The following is a description of a gene set: Genes down-regulated in CD8 T cells, acute infection with LCMV-Armstrong: effectors at day 6 versus memory at day 30. Human Gene Set: GSE41867_DAY6_EFFECTOR_VS_DAY30_MEMORY_CD8_TCELL_LCMV_ARMSTRONG_DN species: Homo sapiens from publication Doering TA, Crawford A, Angelosanto JM, Paley MA, Ziegler CG, Wherry EJ (PMID 23159438) During acute viral infections, naïve CD8+ T cells differentiate into effector CD8+ T cells and, after viral control, into memory CD8+ T cells. Memory CD8+ T cells are highly functional, proliferate rapidly upon reinfection and persist long-term without antigen. In contrast, during chronic infections, CD8+ T cells become “exhausted” and have poor effector function, express multiple inhibitory receptors, possess low proliferative capacity, and cannot persist without antigen. To compare the development of functional memory T cells with poorly functional exhausted T cells, we generated longitudinal transcriptional profiles for each., and this is the list of marker genes: LENG8, CPSF7, MCL1 (MCL1 apoptosis regulator, BCL2 family member), RPS27, KRTCAP3, TRAPPC8, HPCAL1, UCKL1, ITK, ATP2A3, UGCG, CHFR, SYF2, VAT1, NRM (NCBI Gene Id 11270), DDX6, CCR7, NUB1, ZFAND6, DUSP5, CLINT1 (NCBI Gene Id 9685), HDAC5, PHC2, INPP5F, WIPI2, PRKCZ, NFE2L2, INPP4A, EIF1, INPP5K, IRF8, BCL10, CD79A (NCBI Gene Id 973), PDE2A, TPK1, UBL3, SIDT2, PCNX3, PHF21A, SMC6, RASA3, TNRC6B, RELB, TAOK3, MAP4K3, RYBP, SPRY1, CD28, ANGPTL1, MYH9, NCOR1, PPP1R16B, APC, CCNI, TXNDC16, ABHD17B, NXF1, RPRD2, SGK3, WDR44, PRDM2 (NCBI Gene Id 82680), VPS11, EXD2, NCOA6, JUND, LCOR (ligand dependent nuclear receptor corepressor), ITGB7, F2R, STX5, ELOVL5, FLT3, ATP10D, LEMD3, PDP1 (NCBI Gene Id 5497), CACUL1, RLIM, PDCD4, LGALS4, KLF7, TPRG1L, TPST2, TTLL3, SRSF5, FCGRT, CERK, ARSK (NCBI Gene Id 153642), ADGRG3, MTA3, RNFT1, CSGALNACT2, FAU, DDX54, SRSF6, WBP1, C1orf54, TENT5C, CIPC, KCTD12, RAPGEF1, KDM5A, EML4, CLNK, BSDC1, RPL17, BHLHA15, CBL, CHD7 (chromodomain helicase DNA binding protein 7), SPTBN1, ENDOD1, TLN1, COBLL1, E4F1, RASGRP2, CROT, LRRC23, SDF2, RUNX2, CHD6, MYSM1, PARP8, TTC5, PHF6 (NCBI Gene Id 84438), ARID5B, DYNLT3, CDK11B, TOP2B, NSD1, SFXN5, MYO1E, TOB1, CAB39, ANKS3, RALGPS2, MXD4, LPIN2 (NCBI Gene Id 9663), TOLLIP, ERP29, EDARADD, TGFBRAP1, CYTH1, SMG6, SLU7 (SLU7 homolog, splicing factor), ABHD2, APOBEC1, FGD2, LRRK2, CDT1, CMIP, ATP1B1, MKNK1, ARHGAP4, ATOSB, GNAQ, AP4B1, CD37, ABI3, ACKR2, SBNO2, DNAH17, HMCES, DMTF1, RAB11FIP2, THBS3, CXXC5, MAFG, PLEKHB2, UNC93B1, ARF6, CDKN2D, FAM53C, ING3, ACAA2, ANKRD13D, TSC22D2 (TSC22 domain family member 2), CEPT1 (choline/ethanolamine phosphotransferase 1), ZC3H11A, GSAP, FBXO30, ITGAL, ADAMTS10, MACIR, GIGYF1, NEK7, EVL, NTAN1, TMEM268, NR3C1, ING2, FAM193B, N4BP2, ZBTB18, PECAM1 (NCBI Gene Id 5175), GALNT6, HIGD2A, UAP1, HPSE, SH3TC1, LAT, ARPIN, IQGAP1